Given this list of marker genes MFN2, AFG3L2, TPP1, ATXN3, ENSG00000288330, MRE11, EEF2, ITPR1, SCYL1, SPTBN2, ATXN1, TGM6, ATXN8OS, ANO10, PDYN, PEX10, ATXN2 (ataxin 2), UBAP1, here is a description of the gene set: The controller signal for saccadic eye movements has two components: the pulse that moves the eye rapidly from one point to the next, and the step that holds the eye in the new position. When both the pulse and the step are not the correct size, a dysmetric refixation eye movement results. Dysmetric saccades Human Gene Set: HP_DYSMETRIC_SACCADES species: Homo sapiens